The following is a description of a gene set: studied in species Homo sapiens Human Gene Set: GSE15930_NAIVE_VS_72H_IN_VITRO_STIM_IFNAB_CD8_TCELL_DN from publication Agarwal P, Raghavan A, Nandiwada SL, Curtsinger JM, Bohjanen PR, Mueller DL, Mescher MF (PMID 19592655) Genes down-regulated in comparison of CD8 T cells at 0 h versus those at 72 h after stimulation with antigen-B7-1. Differentiation of naive CD8 T cells into cytotoxic effector cells requires three distinct signals- antigen (signal 1), costimulation -B7-1 (signal 2) and cytokine, either interleukin-12 or interferon-a/b (signal 3). Interaction of naive CD8 T cells with antigen and B7-1 programs cell division and proliferation whereas the presence of cytokines- IL-12 or IFNa/b promote survival, differentiation and memory establishment. In the absence of signal 3, the cells interacting with antigen/B7-1 undergo tolerance induction. The objective of this study was to elucidate the mechanisms how the provision of signal 3 promotes differentiation and averts tolerance induction in CD8 T cells. Trichostatin A is a pharmacological agent that inhibits histone deacetylase activity, hence regulating chromatin structure and gene expression and differentiation in many cell types. Gene signature profiles of IL-12, IFNa/b and trichostatin A stimulated cells were compared to elucidate the molecular mechanisms of gene regulation. Oligonucleotide microarray analysis is carried out to determine the extent and molecular nature of the CD8 T cell differentiation program induced by IL-12 or IFNa/b in concert with antigen and B7-1 signal., and this is the list of marker genes: BIRC5, NCAPH, RNASEH2B, MTERF2, CLIC4, MLLT3, CENPK, CARS1, PSAT1, TNFRSF9, CKAP5, CNPY2, TIMM9, TMEM97, CKAP2, RBM10, REXO5, DECR1, PSMD12, MX1, CD200, NOCT (NCBI Gene Id 25819), LGALS3, DDX52, KLRK1, IFI30, GZMB, HDHD2, CNTRL, SLC2A1, GTF2H4, NDUFS6, VEGFA, ESF1, HMBS, HAUS4, IL3RA, DCK, CARM1, ZDHHC16, SAAL1, MKI67, SAP30, RNF14, KIF23, GMNN, ACAD9, MAD2L1, SMPD1, RBPJ, MT2A, CFAP418, XPNPEP1, S100A6, MAEA, PTGR1, IL10RA, PREP, POLR3K, TSPAN31, PGAM1, BHLHE40, ELMOD3, TRAFD1, XDH, UNC119, CYTH3, SLC37A4, PDCD2, NDUFS5, SIVA1, CCDC6, RPA3, ARL14EP, RPN1, CSNK2A2 (casein kinase 2 alpha 2), DTD2, SYNGR2, ACOT7, RFC2, FDPS, TUBG1, NUSAP1, DNMT1, UNC119B, IARS1, COMT, CISD1, ARL2 (ADP ribosylation factor like GTPase 2), TRIB3, GFM1, HAX1, DDX1, TPI1, BUB1, GLRX, PLK4, SKAP2, CMPK2, RIOX2, HRAS, SYCE2, PRIM2, BCL2A1, DESI1, MT1E, MTMR9, MCOLN2, LIG1, CDKN2AIPNL, FDFT1, IFITM3, CDK1, TAMM41, GALK1 (NCBI Gene Id 2584), CAPG, KGD4, SPAG5, RFC5, RAD51AP1, CRCP, KIF4A, CHEK1, SH3BGRL, NDUFV1, JMJD6, FKBP2, CHCHD10, TG, OLA1 (Obg like ATPase 1), TGDS, MRPS22, PAFAH1B3, HIP1R, BRCA1, EZH2, TOP2A, CTPS1, LXN, PSPH, DHCR7, ECPAS, PDIA4, PCLAF, NVL, CCR5, IDI1, CKS1B, TPD52L2, SNRNP25 (small nuclear ribonucleoprotein U11/U12 subunit 25), XPOT, SPAG7, CDC20, STK39, ADSS1, MRPL45, MTX2, CYB5B, EIF2AK2, MCM5, BLMH, ALDH18A1, RHOQ, EMC8, LMNB1, PLP2, XCL1, KLHL7, MCM2, RCC1, ANLN (NCBI Gene Id 54443), MRTO4, CYP51A1, PGM1 (NCBI Gene Id 5236), RAD50 (NCBI Gene Id 10111), DDIT4, GTF2E2, FAM162A, PDS5B, RNH1, MRPL17, SERPINB9, HK2, MTHFD2, TACC3, RFC4, MSMO1, IL10RB, RCN2, HPF1, HSDL2, TRIM37, ANXA2, APBA3, POMP, CRTAP, NBN, HASPIN, MRPL18, MFN1